Given this list of marker genes GPR83, SLC25A11, ADRA2A, CACNA1A, SLC1A3, TBL3, NT5M, RPP21, CNTNAP1 (NCBI Gene Id 8506), STMN1, GBP2, PCDH1, MAFK, GPRC5B, SAC3D1, CCL24, GPX6, APOBEC1, FABP9, DIRAS1, POF1B, GRIK1, MUSTN1, PBDC1, SHCBP1, MYOZ1, HTATIP2, SLC12A3, ALCAM, RABEP1, POSTN, FLNC, ETV4, ABHD14B, UFM1, B3GALT5, MACROH2A1, CA13, UBD, G3BP2, CCL2, SLC7A3, RTKN2, IHH, NINJ1, ECEL1, HLA-G, HNF1A, KAZALD1, ERGIC1 (NCBI Gene Id 57222), ELP2, CKAP5, KLK8, KPNA3, KRT2, SDC4, PDK3, GLUD1, ETV3, TPX2, IL15RA (NCBI Gene Id 3601), SLC30A3, GPC6, ALLC, PRAP1, HEMK1, ZNF124, ELAVL3, PTPRN, BATF2, VCF1, SIX3, PLPBP, PSTPIP1, HLA-DMA, AIRN, PTGS2, FPR3, RNASE3, PHLDA2, RCC2, CASP3, NCKAP1L, CDKN2C, SH3YL1, TOR3A, IFT172 (NCBI Gene Id 26160), STK4, CLDN15 (NCBI Gene Id 245814), CIITA, KIFC3, AKR1B1, KRT82, TENT5C, PRPF38A, SOSTDC1, MYL4, IL4I1, SAA4, SH3TC1, CCL5, EPHA1, RBM3, ZBTB45, CPB1, ECE1, AP2B1, CABYR, TRDN, NFKBIB, B3GALT1, ZYX, CRABP2, IRGM, LITAF, CELA2A, ERN2, SUCO, CEP95, MIPOL1, H1-2, EGR4, ITGA9, SIN3B, MMS19, DAXX, TNNT2, MIDN, DOCK6, BID, TINAGL1, OSGIN2, LOXL4, CGA, KDR, EOMES, MSH5, PDE3A, AMY2A, TEAD1, KEAP1, CDC37, ARF5, NHERF2, DES, RGL1, STMN3, ELAVL2, TGM2, IGF2BP2, ARHGEF10L, RTN4IP1, EGLN2, CPNE2, NES, SRSF11 (serine and arginine rich splicing factor 11), CAPG (capping actin protein, gelsolin like), SMAP2 (NCBI Gene Id 64744), ZNHIT1, INVS, PMVK, TCTE1, KCTD14, TCF15, ABCC6 (ATP binding cassette subfamily C member 6), INTS4, CIDEB, SULT1B1, PKP1, DBNDD1, VTN, CACHD1, VSX1, ZFP90, GBP7, C11orf96, TLR9, GHITM, HLA-E, ACER1, MTSS1, CARD19, GNGT1 (G protein subunit gamma transducin 1), PDZRN3, VCAM1, NDUFS4, WNT5A, CHST7, SDAD1, GAB1, SLC35F6 (solute carrier family 35 member F6), LPIN1 (NCBI Gene Id 23175), CD81, ADGRE5, MYF5, MPND, ETV6, FGL2, DPYSL3, ZNF142, here is a description of the gene set: from publication Amit I, Garber M, Chevrier N, Leite AP, Donner Y, Eisenhaure T, Guttman M, Grenier JK, Li W, Zuk O, Schubert LA, Birditt B, Shay T, Goren A, Zhang X, Smith Z, Deering R, McDonald RC, Cabili M, Bernstein BE, Rinn JL, Meissner A, Root DE, Hacohen N, Regev A (PMID 19729616) Human Gene Set: GSE17721_CPG_VS_GARDIQUIMOD_12H_BMDC_UP mouse primary BMDCs were stimulated with tlr ligands and gene expression changes were profiled on Affymetrix arrays Genes up-regulated in comparison of dendritic cells (DC) stimulated with CpG DNA (TLR9 agonist) at 12 h versus DC cells stimulated with Gardiquimod (TLR7 agonist) at 12 h. species: Homo sapiens